Given this list of marker genes MAPKAP1, FOXO4, CASP9, PDPK1, AKT1S1, FOXO3, GSK3B, MDM2, TSC2, AKT3, AKT1, CDKN1B, FOXO6, GSK3A, AKT2, BAD, CREB1, PRR5, MLST8, RPS6KB2, CHUK, FOXO1, NR4A1, MTOR, CDKN1A, RICTOR, here is a description of the gene set: Reactome Pathway: Constitutive Signaling by AKT1 E17K in Cancer studied in species Homo sapiens While AKT1 gene copy number, expression level and phosphorylation are often increased in cancer, only one low frequency point mutation has been repeatedly reported in cancer and functionally studied. This mutation represents a substitution of a glutamic acid residue with lysine at position 17 of AKT1, and acts by enabling AKT1 to bind PIP2. PIP2-bound AKT1 is phosphorylated by TORC2 complex and by PDPK1 that is always present at the plasma membrane, due to low affinity for PIP2. Therefore, E17K substitution abrogates the need for PI3K in AKT1 activation. part of: PI3K/AKT Signaling in Cancer